Given this list of marker genes Thumpd2, Trmt11, Wdr4, Trmt6, Trmt10c, Trmt61a, Mettl1, Trmt112, Hsd17b10, here is a description of the gene set: Mouse Gene Set: GOCC_TRNA_METHYLTRANSFERASE_COMPLEX A multimeric protein complex involved in the methylation of specific nucleotides in tRNA. studied in species Mus musculus